The following is a description of a gene set: Combining with a nucleotide and transmitting the signal from one side of the membrane to the other to initiate a change in cell activity. A nucleotide is a compound that consists of a nucleoside esterified with a phosphate molecule. species: Homo sapiens Human Gene Set: GOMF_NUCLEOTIDE_RECEPTOR_ACTIVITY, and this is the list of marker genes: P2RY14, P2RY11, GPR34, P2RY12, PTAFR, P2RY8, P2RX5, P2RX4, P2RX7, GPR87, P2RX3, P2RY4, P2RX6, P2RX1, P2RY13, P2RY6, P2RY1, GPR171, P2RX2, P2RY2